Given this list of marker genes UCHL1, KARS1, NKX6-2, PRNP, EIF2AK2, PIGA, PIGT, SPG11, GABRG2, NAA10, RNU12, SLC2A1, HSPD1, SPTBN1, CACNA1H, FMR1, GAMT, KIF1C, CACNA1A, GPR88, TMEM63A, VAMP1, VPS13A, SPTLC1, SIGMAR1 (NCBI Gene Id 80768), PI4KA, GABRA1, POLR1A, TTPA, GJC2, GABRB3, PLP1, ALS2, PEX10 (peroxisomal biogenesis factor 10), LAMA1, MAPT, AARS1, FUS, HIBCH, JRK, LMNB1, DLAT, here is a description of the gene set: species: Homo sapiens Human Gene Set: HP_ABNORMAL_HEAD_MOVEMENTS Abnormal head movements